The following is a description of a gene set: A renal system process in which proteins are taken up from the collecting ducts, glomerulus and proximal and distal loops of the nephron. In non-mammalian species, absorption may occur in related structures (e.g. protein absorption is observed in nephrocytes in Drosophila, see ). species: Mus musculus Mouse Gene Set: GOBP_RENAL_PROTEIN_ABSORPTION, and this is the list of marker genes: Comt, Rhpn1, Kirrel1, Ctns, Dab2, Amn, Ednrb, Adipoq, Gsn, Ednra, Gas6, Edn1, Cd2ap